The following is a description of a gene set: Genes having at least one occurrence of the motif NSGGGGGGGGMCN in the regions spanning 4 kb centered on their transcription starting sites. This matches the transcription factor binding site V$MAZR_01 (v7.4 TRANSFAC). species: Homo sapiens Human Gene Set: MAZR_01, and this is the list of marker genes: APBA1, PRRT2, CLUH, ABR, ZER1, NPTX1, HOXB7, MTF1, RFX1, CKMT1B, VASP, EPHB2, STC2, PIM1, SRF, TLK2, FBXL19-AS1, SLC4A2, ZIC4, RAB1B (NCBI Gene Id 81876), NOTCH2, SSBP2, EIF4G1, TRIM41, FOXJ2, DMPK, RAPGEFL1, RGL2, HOXB9, HNF1A, CHD4, GNB2, CAMK2G, MIR22HG, GART, JUNB, KREMEN2, LRRTM4, PCF11, MAPT, EFNA1, NEUROD2, ITGA6, SEPTIN3, PHF23, SLC22A17, OTUD7B, VCAN, NFYC, UBE4B, GRIN2D, RBL1, MED13, CCDC24, SRCIN1, HMX1, STAU1, SLC2A4, RAB5C, TNFSF12-TNFSF13, MOV10, GRIK1, HOXC6, ADGRB2, HR, URGCP, PHLDB3, TCF7L2, SLITRK5, ZCCHC24 (zinc finger CCHC-type containing 24), CLCN6, RND2, MMP1, DNMT3A, PAFAH1B1, NTN3, ETF1 (NCBI Gene Id 9190), KCND3, MTHFR, VEZF1, DLL3, RTN3, UBA1, HNRNPDL, TMEM59L, EIF5A, TMEM119, LINGO1, ATF2, NOTCH2NLA, GTPBP2 (GTP binding protein 2), KMT2E, BAZ2A, DDAH2, RTN2, UTP18, MEIS2, EYA1, TRPS1, KCNH2, MYBPH, GGN, THPO, ROCK1, L1CAM, SLC39A5, WFIKKN1, PAX6, FXYD3, HOXC4, GATA6, PTPRF, LIN28A, HTN1, PRKCG, MEX3B, FUS, KDM6A, NCOA2, TNPO2, ZNF513, MKNK2, GPR173, WDR81, RNF111, SF1, CTNNBIP1, GRK5, CLIC1, TNFSF12, ETV5, P4HTM, DLL4, AEBP2, IRF2BPL, SON, ZNF503, HMGA1, PRRC2A, ZMYM2, MIEN1, ATF1, KRT17, PACSIN3, HOXB6, PHF12, WNT1, FXYD1, ARHGAP44, LUC7L2, FXR2 (FMR1 autosomal homolog 2), ZNF462, POU3F2 (POU class 3 homeobox 2), GABARAPL2, LRFN5, IL1RAPL1, FBXL19, SLC39A2, FGF14, SLC9A7, SEMA4C, TAGLN3, PLA2G2E, ORAI2, FAM117A, SULT2B1, SALL1, NLGN2, PARD6G, UBE2R2, MAGED2, ENTPD1, NETO1, HSD11B1, SCUBE3, TRERF1, MPC2, EZH2, HNRNPR, FOXA1, PHF21A, KCNK6, RAP2C, CBFB, HHATL, CORO1C, GABPB2, UST, JAKMIP2, HPCA, AHR, FBRS, POGZ, NXPH4, TRIP10, SYT3, MBD6, ATXN7L2, FGF17, ENSA, CACNB1, TMEM255A, RAB11B (NCBI Gene Id 9230), JPH4, PPM1J, WDR48 (NCBI Gene Id 57599), ELOC, DUSP8, NLK, BRME1, LGALS1 (galectin 1), MBD3, MLLT6, H1-0, CDC27, FKBP2, ZBTB26, SP1, EPB41L3, PCBP4, HNRNPUL1, FAF2, CLOCK, TCP11L2 (NCBI Gene Id 255394)